Given this list of marker genes Grik2, Lrp11, Kcnk4, Trpm2, Cidea, Hspb6, Akt1, Ano1, Chrna7, Rasa3, Comt, Lipe, Ngfr, Tfec, Ckm, Hsbp1, Wdr47, Abraxas2, Vcp, Ano3, Trpm8, Acadm, Stac, Adora1, Hsp90aa1, Acadvl, Pdcd6, Aldh18a1, Dnaja4, Cdh8, Plin1, Rnf170, Vgf (VGF nerve growth factor inducible), Ntrk1, Appl2, Nfe2l1, Igf1, Trpa1, Slu7, Pparg, Pcsk1n, Crnn, Slc25a27, Hspb2, Hspb1, Hspd1, Il1r1, Trpv1, Osm, Mapt, Rbm3, Hikeshi, Fgf1, Lncbate10, Eif2b5, Rho, Clpb, Dnajb1, Atp1a3, Drgx, Scn9a, Calca, Gclc, Adrb2, Ephb1, Prdm12, Hsf1, Lyn, Ucp2, St8sia1, Thra (thyroid hormone receptor alpha), Opn4, Nrg1, Dnaja2, Mcrip2, Metrnl, Cdkn1a, Bag3, Hspa1a, Disc1, Eif2b4, Hsf3, Saxo1, Acot11, Prkaca, Arpp21, P2rx3, Nr2f6, Ptgs2 (prostaglandin-endoperoxide synthase 2), Eif2ak4, Cryaa, Tac4, Eif2s1, Myof, Slc9a1 (NCBI Gene Id 20544), Dnaja3, Bltp1, Scn10a, Hsp90ab1, Casq1, Mill1, Tlr4, Pmp22, Ucp1, Ier5, Irak1, Eef1d, Trp53inp1, Pirt, Cirbp, Sod1, Arrb2, Pdcl3, Slco1b2, Agt, Asic3, Trpv3, Dhx36, Rnf34, Cryab, Scn11a, Daxx, Tac1, Hmox1, Slc27a1, Pawr, Kcnq2, Htr2a, Mmp24 (NCBI Gene Id 99226), Lipa, Tcim, Eif2ak3, Slc12a5, Il1a, Scrn3, Eif2b2, Ywhae, Htra2, Prkaa1, Tmem135, Psip1, Ces1d, Cxcl12, Slc52a3, Chordc1, Zfp516, Eif2b3, Hspa8, Trpv2, Ucp3, Eif2b1, Trpv4, Cetn1, Nos1, Mtor, Cxcr4, Acadl, Sumo1, Lxn, Tpr, Hpcal4, Ntsr1, Atxn3, Rbbp7, Fcor, Hspa1b, Nf1 (neurofibromin 1), Dhx9, Adrb3, Hmgcs2, Zfp976, Dnajc3 (DnaJ heat shock protein family (Hsp40) member C3), Plac8, Adrb1, Cntnap2, Scn2b, Xylt1, Scara5, Hspa2, Dnaja1, Map2k7, Hsbp1l1, here is a description of the gene set: studied in species Mus musculus Mouse Gene Set: GOBP_RESPONSE_TO_TEMPERATURE_STIMULUS Any process that results in a change in state or activity of a cell or an organism (in terms of movement, secretion, enzyme production, gene expression, etc.) as a result of a temperature stimulus.